The following is a description of a gene set: studied in species Homo sapiens The cell cycle process in which chromatin structure is compacted prior to and during mitosis in eukaryotic cells. Human Gene Set: GOBP_MITOTIC_CHROMOSOME_CONDENSATION, and this is the list of marker genes: TENT4A, SMC4, NCAPG, NCAPH, SMARCA5, NCAPH2, NCAPD2, CHMP1A, AKAP8, NCAPD3, SMC2, PHF13, H2BW1, NUSAP1, BAZ1B, KMT5A, TTN, AKAP8L, PLK1